Given this list of marker genes MOG, IQSEC2, TNFSF4, ZNF365, RFC1, DNMT1, PRNP, HCRT, CTSH, RAI1, MAGEL2, FLII, MEN1, COQ2, TRANK1, HLA-DRB1, DEAF1, SIM1, P2RY11, YY1, HLA-DQB1, here is a description of the gene set: species: Homo sapiens Abnormality of REM Sleep are phases of REM sleep are characterized by desynchronized EEG patterns, increases in heart rate and blood pressure, sympathetic activation, and a profound loss of muscle tone except for the eye and middle-ear muscles. There are also phases of rapid eye movements. Abnormal rapid eye movement sleep Human Gene Set: HP_ABNORMAL_RAPID_EYE_MOVEMENT_SLEEP